Given this list of marker genes Rnf2, Gm4870, Mki67, 2700099C18Rik, Gbx2, Bub1, Usp22, Hcfc1, here is a description of the gene set: from publication Glinsky GV, Berezovska O, Glinskii AB (PMID 15931389) Mouse Gene Set: GLINSKY_CANCER_DEATH_UP Activation in transformed cells of normal stem cells' self-renewal pathways might contribute to the survival life cycle of cancer stem cells and promote tumor progression. The BMI-1 oncogene-driven gene expression pathway is essential for the self-renewal of hematopoietic and neural stem cells. We applied a mouse/human comparative translational genomics approach to identify an 11-gene signature that consistently displays a stem cell-resembling expression profile in distant metastatic lesions as revealed by the analysis of metastases and primary tumors from a transgenic mouse model of prostate cancer and cancer patients. To further validate these results, we examined the prognostic power of the 11-gene signature in several independent therapy-outcome sets of clinical samples obtained from 1,153 cancer patients diagnosed with 11 different types of cancer, including 5 epithelial malignancies (prostate, breast, lung, ovarian, and bladder cancers) and 5 nonepithelial malignancies (lymphoma, mesothelioma, medulloblastoma, glioma, and acute myeloid leukemia). Kaplan-Meier analysis demonstrated that a stem cell-like expression profile of the 11-gene signature in primary tumors is a consistent powerful predictor of a short interval to disease recurrence, distant metastasis, and death after therapy in cancer patients diagnosed with 11 distinct types of cancer. These data suggest the presence of a conserved BMI-1-driven pathway, which is similarly engaged in both normal stem cells and a highly malignant subset of human cancers diagnosed in a wide range of organs and uniformly exhibiting a marked propensity toward metastatic dissemination as well as a high probability of unfavorable therapy outcome. Genes whose over-expression is associated with the risk of death in multiple cancer types studied in species Mus musculus